Given this list of marker genes DNAJA1, RDH11, SRSF7, EIF1AXP1, PABPC4 (poly(A) binding protein cytoplasmic 4), RRM2, DNAJB1, SRSF3, HSPH1, HSPA8, HSPA1L, HSPA2 (heat shock protein family A (Hsp70) member 2), here is a description of the gene set: Genes down-regulated in EVSA-T cells (breast cancer) treated with 5 micromolar THC (delta-9-tetrahydrocannabinol) for 8 h. Human Gene Set: CAFFAREL_RESPONSE_TO_THC_8HR_5_DN It has been recently shown that cannabinoids, the active components of marijuana and their derivatives, inhibit cell cycle progression of human breast cancer cells. Here we studied the mechanism of Delta(9)-tetrahydrocannabinol (THC) antiproliferative action in these cells, and show that it involves the modulation of JunD, a member of the AP-1 transcription factor family. THC activates JunD both by upregulating gene expression and by translocating the protein to the nuclear compartment, and these events are accompanied by a decrease in cell proliferation. Of interest, neither JunD activation nor proliferation inhibition was observed in human non-tumour mammary epithelial cells exposed to THC. We confirmed the importance of JunD in THC action by RNA interference and genetic ablation. Thus, in both JunD-silenced human breast cancer cells and JunD knockout mice-derived immortalized fibroblasts, the antiproliferative effect exerted by THC was significantly diminished. Gene array and siRNA experiments support that the cyclin-dependent kinase inhibitor p27 and the tumour suppressor gene testin are candidate JunD targets in cannabinoid action. In addition, our data suggest that the stress-regulated protein p8 participates in THC antiproliferative action in a JunD-independent manner. In summary, this is the first report showing not only that cannabinoids regulate JunD but, more generally, that JunD activation reduces the proliferation of cancer cells, which points to a new target to inhibit breast cancer progression. from publication Caffarel MM, Moreno-Bueno G, Cerutti C, Palacios J, Guzman M, Mechta-Grigoriou F, Sanchez C (PMID 18454173) species: Homo sapiens